The following is a description of a gene set: species: Homo sapiens Refers to the loss of the outer layer of the epidermis in large, scale-like flakes. Human Gene Set: HP_SCALING_SKIN Scaling skin, and this is the list of marker genes: LORICRIN, TGM5, CARD14, RECQL, ELOVL4, FLG2, KIF11, LDHA, MPDU1, KIT, CDSN, IL7R, RNF168, GJB2, GJB6, IL2RA, KLK11, PKP1, MBTPS2, EBP, SASH1, CAST, KRT1, SULT2B1, GJA1, SERPINB8, RASA1, CSTA, CASP14, NIPAL4, DSP, KRT10, EGFR (epidermal growth factor receptor), OSMR, RIGI, LMNA, TGM1, KRT74, PPP2R3C, LRBA, ADAM17, CARMIL2, ZMPSTE24, SAMHD1, CYP4F22, MPV17, GNB2